The following is a description of a gene set: Myeloid dendritic cells (DC) and macrophages play an important role in pathogen sensing and antimicrobial defense. Recently we demonstrated that infection of human DC with intracellular bacterium Listeria monocytogenes (L.monocytogenes) leads to the induction of the immunoinhibitory enzyme indoleamine 2,3-dioxygenase (Popov et al., J Clin Invest, 2006), while in the previous studies L.monocytogenes infection was associated with a rather stimulatory DC phenotype. To clarify this discrepancy we performed comparative microarray analysis of immature mo-DC (immDC), mature stimulatory mo-DC (matDC) and mature inhibitory DC either stimulated with prostaglandin E2 (PGE2-DC) or infected with L.monocytogenes (infDC). Studying infection of human myeloid DC with Listeria monocytogenes, we found out, that infected DC are modified by the pathogen to express multiple inhibitory molecules, including indoleamine 2,3-dioxygenase (IDO), cyclooxygenase-2, interleukin 10 and CD25, which acts on DC as IL-2 scavenger. All these inhibitory molecules, expressed on regulatory DC (DCreg), are strictly TNF-dependent and are in concert suppressing T-cell responses. Moreover, only DCreg can efficiently control the number of intracellular listeria, mostly by IDO-mediated mechanisms and by other factors, remaining to be identified. Analyzing publicly acessible data of transcriptional changes in DC and macrophages, infected by various pathogens and parasites (GEO, GSE360), we noticed that infection of these cells with Mycobacterium tuberculosis causes transcriptional response, comparable with the one caused by listeria in human DC. In fact, granuloma in tuberculosis and listeriosis in vivo are enriched for myeloid DC and macrophages characterized by regulatory phenotype. In summary, regulatory myeloid DC and macrophages may play a dual role during life-threatening granulomatous infections, such as tuberculosis: on one hand, regulatory myeloid cells promote pathogen containment by efficiently killing intracellular bacteria, on the other hand these cells inhibit granuloma-associated T cells and thereby might be involved in the retention of TNF-controlled granuloma integrity protecting the host from granuloma break-down and pathogen dissemination. studied in species Homo sapiens from publication Popov A, Driesen J, Abdullah Z, Wickenhauser C, Beyer M, Debey-Pascher S, Saric T, Kummer S, Takikawa O, Domann E, Chakraborty T, Krönke M, Utermöhlen O, Schultze JL (PMID 18802101) Genes up-regulated in mature dendritic cells: stimulatory versus inhibitory infected with L. monocytogenes. Human Gene Set: GSE9946_MATURE_STIMULATORY_VS_LISTERIA_INF_MATURE_DC_UP, and this is the list of marker genes: PPP1R15B, PJA1, RPUSD4, EIF4B, RUNX3, CRP (C-reactive protein), PRR3, CLTA, EIF4EBP2, GGCT, PML, SH3BP5, MRPL46, ZFYVE19, TMCC1, LRIG3, HDHD2, ECSIT, NCOR2, NEK9, ZBTB49, ITPKC, UPF3A, NKAPL (NCBI Gene Id 222698), ALKAL1, ATXN7L1 (ataxin 7 like 1), NUP210, PPP1R21, RNF222, ZFYVE1, NDUFS5, PDLIM5, SLC45A2, TSPAN1, DAG1, AGK (acylglycerol kinase), TGFBR3, SLC35E1, AMIGO3, ZCCHC3, ZBTB7A, SAP30BP, SIPA1L3, FAM117B (family with sequence similarity 117 member B), NELFA, DCTN1, CLCA4, PSME2, F2RL1, CCDC32, SNIP1, MAN2B2, NPW, LEF1, TBC1D9B, CTNS, MARVELD3, CNGA1, AFG3L1P, FAM168B, IL6ST, PLEKHM1, PLAAT3, VEZT, ATP6V0D1, SMAD7, DNTTIP1, PRKAR2A, CCDC70, TLE1, JOSD2, FMO5, SLC66A1, RAD52, PIGK, PDLIM2, CUX1, MAP3K3, H2BC21, ANKS6, AP1M1, GLG1, SP2, GRB7, LFNG, GNS, IL1RAP, GPRC5B, ZC2HC1A, NDRG3, TMEM81, SPATA2L, NMRK1, GEMIN8, FFAR4, C2CD6, KRBA1, NAF1, TRIM40, MED15, MAF, TOR3A (NCBI Gene Id 64222), SETD1B, DIS3L2, RHOG, MIR340, ORM1 (NCBI Gene Id 5004), RIN3, DAPK3, TRPC5, TRMT5, EIF2B5, TTC7B, CCDC115, TM2D2, DSE, TMCO2, SUFU, RPS8, RRS1, EXO5, PHF2, CHMP7, SMAD3, DYNLT5, FCGR3A, KBTBD3, NIPAL1, MOSPD3